Given this list of marker genes MIR98 (microRNA 98), MIR181D, CARD8, CARD16, CARD17P, GHSR, TREM2, MIR101-1, MIR708, NLRP2B (NCBI Gene Id 286430), GHRL, RAD21, ARRB2, MIR920, CARD18, MIR488, SERPINB1, MIR204, CX3CL1, ERRFI1, NLRP3 (NLR family pyrin domain containing 3), CX3CR1, MIR195, CPTP, MIR132, PYDC1, MIR27B, APOA1, ZC3H12A, GIT1, MIR766, GSTP1 (glutathione S-transferase pi 1), TNFAIP3, PML, MIR181A2, MEFV, ACP5, IGF1, PYDC2, LILRB4, MIR877, CD33, NLRP7, FFAR4, FFAR1, ELF4 (NCBI Gene Id 2000), here is a description of the gene set: Any process that stops, prevents, or reduces the frequency, rate, or extent of interleukin-1 beta production. studied in species Homo sapiens Human Gene Set: GOBP_NEGATIVE_REGULATION_OF_INTERLEUKIN_1_BETA_PRODUCTION